The following is a description of a gene set: Cluster P2 of genes with similar expression profiles in peripheral T ymphocytes after FOXP3 loss of function (LOF). studied in species Mus musculus from publication Gavin MA, Rasmussen JP, Fontenot JD, Vasta V, Manganiello VC, Beavo JA, Rudensky AY (PMID 17220874) Human Gene Set: GAVIN_FOXP3_TARGETS_CLUSTER_P2 Regulatory CD4+ T cells (Tr cells), the development of which is critically dependent on X-linked transcription factor Foxp3 (forkhead box P3), prevent self-destructive immune responses. Despite its important role, molecular and functional features conferred by Foxp3 to Tr precursor cells remain unknown. It has been suggested that Foxp3 expression is required for both survival of Tr precursors as well as their inability to produce interleukin (IL)-2 and independently proliferate after T-cell-receptor engagement, raising the possibility that such 'anergy' and Tr suppressive capacity are intimately linked. Here we show, by dissociating Foxp3-dependent features from those induced by the signals preceding and promoting its expression in mice, that the latter signals include several functional and transcriptional hallmarks of Tr cells. Although its function is required for Tr cell suppressor activity, Foxp3 to a large extent amplifies and fixes pre-established molecular features of Tr cells, including anergy and dependence on paracrine IL-2. Furthermore, Foxp3 solidifies Tr cell lineage stability through modification of cell surface and signalling molecules, resulting in adaptation to the signals required to induce and maintain Tr cells. This adaptation includes Foxp3-dependent repression of cyclic nucleotide phosphodiesterase 3B, affecting genes responsible for Tr cell homeostasis., and this is the list of marker genes: CRYBG2, ITGA4, NEURL3, SIGMAR1, TBX21, VDR, BMP7, TNFSF8, PRR5L (proline rich 5 like), RAMP1, LIME1 (Lck interacting transmembrane adaptor 1), DSP, ST6GALNAC1, IL17A, SANBR, EPS15, IQCC, SLFN5, SLC2A8, IGFBP7, KLK1, BTG1, PCM1, KIF23, FAM20A, LDHD, MBNL3, GALNS, CPE, PRICKLE1, DAW1, RGS11, PEX3, TMEM38B, MYO6, LY6K, CD7, NCKAP1L, GSTT2, AIRN, CPM, FIRRM, TMEM176B, RAB6B, GEMIN5, CHST15, PELI1, BCL2, CCL20 (C-C motif chemokine ligand 20), PSTPIP2, SEC61A2, OTUD4, MTMR9, C3orf70, CXCR3, GUCY1B1, CTSE, PADI2, BICC1, ABCB1, CXCR5, SIK1, TM6SF1, TXNL4A, CEP192, GAA, CASP4, ARSB, CD200R1, IFI44L (NCBI Gene Id 10964), ADAT2, GJA1, SERPINB1, LCK, FOXN3, SS18, CCL5, FCGR2A, CD22, PTGER3 (NCBI Gene Id 5733)